The following is a description of a gene set: We used microarray to compare gene expression between CD161++/CD161+/CD161-CD8+ T cells from human cord blood. from publication Walker LJ, Kang YH, Smith MO, Tharmalingham H, Ramamurthy N, Fleming VM, Sahgal N, Leslie A, Oo Y, Geremia A, Scriba TJ, Hanekom WA, Lauer GM, Lantz O, Adams DH, Powrie F, Barnes E, Klenerman P (PMID 22086415) species: Homo sapiens Human Gene Set: GSE33424_CD161_HIGH_VS_INT_CD8_TCELL_DN Genes down-regulated in CD8 T cells: KLRB1 high versus KLRB1 int., and this is the list of marker genes: ADA, SFMBT2, RCN1, MYO6, CD9, P3H3, ATOX1, SPR, SEMA4F, SAR1B (secretion associated Ras related GTPase 1B), HLA-DRA, MYBL2, DRC1, ELOVL6, SMDT1, CDK5RAP3, PALM (NCBI Gene Id 5064), AIRE, EDEM1, RAB8B, MCM2, IGFBP1, CKAP2, RACGAP1 (Rac GTPase activating protein 1), NDUFA5, CD28, PPA1, SST, RPL41, FLOT1, CD8B, EZH2, STAT5B, PGK1, FAS, SNHG6, AHCY, CD3G, RAD51, SLC25A4, KIF20A, CDCA3, ANXA2, PKP4, HES2, DDC, THY1, ACTN2, FBLN1, RAMP1, CDC25C, ITK, NCAPH, RGS11, AGRP, PPIA, SELPLG, ZSCAN12, TOP2A, FOXN2, OTULINL, CD3D, TUBA1B, ORC6, IGF2R, UQCRQ, IL7R, ATP5IF1, METTL9, ALYREF, NOTCH1, MYBBP1A, S100A10, CDK1, CSNK2A1 (NCBI Gene Id 1457), KIF22, NUDT1 (nudix hydrolase 1), HNRNPLL, PGAM1, NDUFB6, SSBP2, TUBB, ADAM19, PCLAF, PSPH, G0S2, TBC1D24, NDUFA2, DIAPH3, SFXN1 (sideroflexin 1), CNGA1 (cyclic nucleotide gated channel subunit alpha 1), RNF149, CST7, KRT7, EEF1AKMT1, SLC46A1, PRSS58, NUSAP1, HPCAL1, PFKP, ITM2A, CCNA2, ACTN1, CBR1, CBX6, IFITM10, PLG (NCBI Gene Id 90749), RWDD4, CCND2, CCNB2, FADS1 (fatty acid desaturase 1), PTGS2, CD8A, PDLIM1, MS4A6A, CUTA, AQP9, BZW2, ARL4C, BAG6, RGS10, SLC25A10, CKS1B, PARM1, LSM7, MYL1, NFIX, NSG2, NPC2, RPS26, ATP5MK, COL4A1, GALK2, TDRP, CELSR1, F2R, LMX1B, RGCC, PTPN13, MTR, UCK2, TUBA1A, SIT1, CCT7, TENT5C, SRCIN1, THOC7, RANBP1, HCN3, TCF7, PTPN22, GOSR1, IFI27, TSPO, RECK, EXO1, SH3PXD2A, EMB, MRPL41, RRP7A, MATN1, SELENOV, STMN1, MRPL27, MRPS28, CDC20, XRCC1, NCKAP1, TXN, GFI1, NRP1, H3-4, MRPS14, ARAP3, C8orf33, VPS26B, MRPL54, ZAP70, ACKR1, TNFAIP8L1, NCBP1, CMC2, DHCR24, ITGAE, CHEK1, PTOV1, USP3, NFE2, SUPT4H1, S100A6, TXK, FXYD5, SOCS3, CTLA4, S100A4, BAG2, IGFBP7, ANGPTL2, PRDX6, YJU2